Given this list of marker genes SRD5A1, SOX3 (NCBI Gene Id 8256), TSC1, LHX5, PROP1, CDK5R2, LEF1, SRF, LRP8, KDM6B (lysine demethylase 6B), NCOA1, ATP1A2, ATG16L1, EZH1, SEMA3E, FBXO41, GSK3B, NDNF (NCBI Gene Id 79625), ATP2B4, TSKU, PTPRS, XRCC1, CDK5, FGF13, DLX2, LMX1A, POU3F2, TMEM108, MKKS, OTP, VPS13B, CTNNB1, KCNA1, SMO, NEFL, KIF14, HTR5A, CRKL, RARA, EPHA5, EIF2B5, PAFAH1B1, TBR1, PHLPP2, PLXNA3, CFL1, LARGE1 (LARGE xylosyl- and glucuronyltransferase 1), BLOC1S6, TP73, MFSD2A, NKX2-1, TUBA1A, SEMA6B, EMX2, BBS4, DRD1, RELN, FEZ1, PITX2, BCAN, CDK5R1, PLXNA1, GLI3, NR0B1, RAB3GAP1, CASP3, SRD5A2, WNT3A, DAB1, ATAT1, PROX1, CRK, HAP1, FGFR1, BTG2, FGFR2, ALDH1A3, PPP1R9B, RAX, FXR1, SCT, MDK, NF1, NKX2-6, PRDM13, POMT2, XRN2, GSX1, ALK, FEZF2 (FEZ family zinc finger 2), UQCRQ, DCLK2, FOXB1, PTEN (phosphatase and tensin homolog), FXR2, ZIC1, DLX1, SLC32A1, YWHAE, NEUROD1, BBS1, DRD2, NR4A3, ID4, NRP1, UBB, HDAC1, NEUROD6, TBX3, NF2, BBS2, CRH, NRP2, NR2E1, POMGNT1, CNTNAP2, OGDH, KIRREL3, CDK6, BAX, ZEB2, NHLH2, ZIC3, RAN, EZH2, PIANP, here is a description of the gene set: The progression of the limbic system over time from its initial formation until its mature state. The limbic system is a collection of structures in the brain involved in emotion, motivation and emotional aspects of memory. species: Homo sapiens Human Gene Set: GOBP_LIMBIC_SYSTEM_DEVELOPMENT